The following is a description of a gene set: Mouse Gene Set: GOBP_CELLULAR_RESPONSE_TO_LEUCINE_STARVATION studied in species Mus musculus Any process that results in a change in state or activity of a cell (in terms of movement, secretion, enzyme production, gene expression, etc.) as a result of deprivation of leucine., and this is the list of marker genes: Atf4, Sesn1, Sar1a, Sar1b, Rnf167, Atf2, Lars1, Rragd, Sesn3, Mtor, Rragb, Sesn2